The following is a description of a gene set: Mouse Gene Set: GOBP_EXTRINSIC_APOPTOTIC_SIGNALING_PATHWAY_VIA_DEATH_DOMAIN_RECEPTORS The series of molecular signals in which a signal is conveyed from the cell surface to trigger the apoptotic death of a cell. The pathway starts with a ligand binding to a death domain receptor on the cell surface, and ends when the execution phase of apoptosis is triggered. studied in species Mus musculus, and this is the list of marker genes: Brca1, Psen2, Casp8ap2, Casp8, Park7, Zswim2, Fgg, Tnfrsf1a, Dedd, Itprip, D1Pas1, Icam1, Daxx, Pea15a, Nf1, Cflar, Zdhhc3, Mal, Trps1, Tnfrsf23, Fga, Stk3, Tmbim1, Dedd2, Dele1, Sfrp1, Spi1, Ripk1, Tradd, Bad, Pik3r1, Bag3, Sfrp2, Stk4, Lgals3, Tnf, Bcl2l10, Bcl2, Fasl, Stx4a, Sort1, Nol3, Bmpr1b, Atf3, Hmgb2, Gabarap (NCBI Gene Id 56486), Bex3, Faim2, Hmox1, Dapk1, Gpx1, Madd, Il18 (NCBI Gene Id 16173), Serpine1, Fas, Pmaip1, Moap1, Skil, Ddx3x, Tnfrsf10b, Rnf34, Sp100, Rffl, Rock2, Pidd1, Faim, Grina, Ddx47, Faf1, Fadd, Bcl2l1 (NCBI Gene Id 12048), Fem1b, Faiml, Dab2ip, Bloc1s2, Raf1, Gsk3b, Tnfrsf22, Bax, Thbs1 (thrombospondin 1), Fgb, Ngf, Hgf, Tmc8, Tnfaip3, Tnfsf10 (NCBI Gene Id 99628)